Given this list of marker genes SLC2A5 (solute carrier family 2 member 5), TMPRSS3, IL32, LPAR6, CD38, CTSS, PDE4B, CLEC2D, PSPHP1, IGF1, EXOC5 (exocyst complex component 5), NFIL3, ADM, LEF1, DNAJB9, WFDC2, STS, PTPRO, ARL4C, CLEC2B, MAN2A1, here is a description of the gene set: from publication Spielman RS, Bastone LA, Burdick JT, Morley M, Ewens WJ, Cheung VG (PMID 17206142) species: Homo sapiens Genes down-regulated more than two-fold in lymphoblastoid cell lines from European population compared to those from Asian population. Variation in DNA sequence contributes to individual differences in quantitative traits, but in humans the specific sequence variants are known for very few traits. We characterized variation in gene expression in cells from individuals belonging to three major population groups. This quantitative phenotype differs significantly between European-derived and Asian-derived populations for 1,097 of genes tested. For the phenotypes with the strongest evidence of cis determinants, most of the variation is due to allele frequency differences at cis-linked regulators. The results show that specific genetic variation among populations contributes appreciably to differences in gene expression phenotypes. Populations differ in prevalence of many complex genetic diseases, such as diabetes and cardiovascular disease. As some of these are probably influenced by the level of gene expression, our results suggest that allele frequency differences at regulatory polymorphisms also account for some population differences in prevalence of complex diseases. Human Gene Set: SPIELMAN_LYMPHOBLAST_EUROPEAN_VS_ASIAN_2FC_DN